Given this list of marker genes GNB1, GNB2, CCR5, GNG5, GNG4, GNB5, CFL2, GNG2, GNG8 (NCBI Gene Id 94235), LIMK1, GNG7, GNG10, CXCR4, RAC1, GNGT1 (NCBI Gene Id 2792), PAK1, GNB4, GNG11, CFL1 (cofilin 1), GNG12, GNGT2, GNG13, RAC2, RAC3, GNB3, GNG3, here is a description of the gene set: Pathway Definition from KEGG: Env -> (CXCR4,CCR5) -> GNB/G -> RAC -> PAK1 -> LIMK1 -> CFL Human Gene Set: KEGG_MEDICUS_PATHOGEN_HIV_GP120_TO_CXCR4_GNB_G_RAC_SIGNALING_PATHWAY studied in species Homo sapiens HIV gp120 to CXCR4-GNB/G-RAC signaling pathway. Pathway ID: N00434. Pathway type: Pathogen. Pathway class: nt06161 Human immunodeficiency virus 1 (HIV-1).